The following is a description of a gene set: species: Mus musculus Synthesis of epoxy (EET) and dihydroxyeicosatrienoic acids (DHET) Mouse Gene Set: REACTOME_SYNTHESIS_OF_EPOXY_EET_AND_DIHYDROXYEICOSATRIENOIC_ACIDS_DHET, and this is the list of marker genes: Cyp1a2 (NCBI Gene Id 13077), Cyp1a1, Cyp2c65, Cyp1b1, Cyp2j6, Ephx2, Cyp2c66